Given this list of marker genes TRMT5, KNSTRN, MKI67, SPRY1, PLAGL1, SLC39A8, MGAT5, SPP1, LCLAT1, SLC35F5, SLC66A1, SLC19A2, SCAMP1, BMPR2, CTNNA1, GCSH, MAP3K20, SOCS2, KLF9, GPR171, RNF181, TRAIP (TRAF interacting protein), ASF1B, CAPG, MAFG, BCAT1, ABHD4, REEP5, DHFR, RAD51B, RRM2, HLA-DMA, AKR1E2, MAPKAPK3, PPP1R16A (protein phosphatase 1 regulatory subunit 16A), CDCA5, PTPRS, KIF18B, ARFGAP3, CTIF, UMPS, NR4A3, RGS1, SEMA7A, SLC5A3, EIF4EBP1, VCL, IFT57, CEP43, MCM5, GMPR2, IDE, MPZL1, DGCR6, PSAT1, FBXW11, GPR89B, POLE, NICN1, MYO1C, ZNF580 (NCBI Gene Id 51157), SLFN12, SGO1, CCNB2, CISH, IMPDH2, SPC25, NUDT6, ODC1, PSMD1, TCF19, GINS1, PASK, TMPRSS3, DYRK3, CCNA2, NARS1, CREB3L2, GFER, TMCC1, ALCAM, SEPHS1, UBL4A, ALPK2, UXS1, KY, KMT5A, N4BP1, PRNP, CENPK, ASNS, IKZF4, MDFIC (NCBI Gene Id 29969), TIGD2, RHOQ, IL2RA, KIAA1191, CASP3, PLSCR1, EEA1, AARS1, CDK1, CPD, RNF149 (ring finger protein 149), AEN, STMN1, PLP2, CHSY1, FCRL1, TOP2A, GABARAPL1, GJA1, RNMT, EI24, SS18, SNORD89, MRPS6, FABP5, DNA2, EHD4, TXN2 (thioredoxin 2), PPFIBP1, PBK, RRAGD, IFT88, DUSP16, CDK6, NUSAP1, CD38, RUFY3, FRRS1, NUF2, ZBED5, STON1, SLC9B2, GLOD4, MRRF, C9orf72, TOR1AIP2, COX7A1 (NCBI Gene Id 1346), USP27X, LRRC75A, COMMD9, HSPA4L, ALDH18A1, HIVEP3, TDRKH, NCAPH, DUSP4, STIL, AFDN, POLA1, EGLN3, DSN1, ATAD2, TNFRSF1B, IRF4, NUP43, TFDP2, SNHG32, RBPJ, DNAAF4, RACGAP1, TTC39B, DPCD, CINP, GFOD1, CDC6, SLC35B1, LITAF, STAB1, TMEM17, IKZF3, LAMC1, COG6, CKS1B, CKS2, IQCF5, FANCI, AOPEP, IRF8, UBE4B, MT1E, YBX3, POLK, PDK3, ANXA3, LPGAT1, MYB, TMEM214, MAP7, ACOT9, CTLA4, SMYD3, SNX12, ZNF22, PPP2R1B, METTL4, CCHCR1, KIF22, here is a description of the gene set: STAT3, an essential transcription factor with pleiotropic functions, plays critical roles in the pathogenesis of autoimmunity. Despite recent data linking STAT3 with inflammatory bowel disease, exactly how it contributes to chronic intestinal inflammation is not known. Using a T cell transfer model of colitis we found that STAT3 expression in T cells was essential for the induction of both colitis and systemic inflammation. STAT3 was critical in modulating the balance of T helper 17 (Th17) and regulatory T (Treg) cells, as well as in promoting CD4+ T cell proliferation. We used chromatin immunoprecipitation and massive parallel sequencing (ChIP-Seq) to define the genome-wide targets of STAT3 in CD4+ T cells. We found that STAT3 bound to multiple genes involved in Th17 cell differentiation, cell activation, proliferation and survival, regulating both expression and epigenetic modifications. Thus, STAT3 orchestrates multiple critical aspects of T cell function in inflammation and homeostasis. from publication Durant L, Watford WT, Ramos HL, Laurence A, Vahedi G, Wei L, Takahashi H, Sun HW, Kanno Y, Powrie F, O'Shea JJ (PMID 20493732) species: Homo sapiens Genes up-regulated in CD4 T cells with STAT3 knockout: medium versus TGF beta and IL6. Human Gene Set: GSE21670_UNTREATED_VS_TGFB_IL6_TREATED_STAT3_KO_CD4_TCELL_UP